The following is a description of a gene set: The gene expression program underlying the specification of human cell types is of fundamental interest. The study authors generated human cell atlases of gene expression and chromatin accessibility in fetal tissues. For gene expression, the study authors applied three-level combinatorial indexing to >110 samples representing 15 organs, ultimately profiling ~4 million single cells. The study authors leveraged the literature and other atlases to identify and annotate hundreds of cell types and subtypes, both within and across tissues. Our analyses focused on organ-specific specializations of broadly distributed cell types (such as blood, endothelial, and epithelial), sites of fetal erythropoiesis (which notably included the adrenal gland), and integration with mouse developmental atlases (such as conserved specification of blood cells). These data represent a rich resource for the exploration of in vivo human gene expression in diverse tissues and cell types. Marker genes curated from the annotated cluster as represented in the Descartes Human Gene Expression During Development database. studied in species Homo sapiens Human Gene Set: DESCARTES_MAIN_FETAL_INHIBITORY_NEURONS from publication Cao J, O'Day DR, Pliner HA, Kingsley PD, Deng M, Daza RM, Zager MA, Aldinger KA, Blecher-Gonen R, Zhang F, Spielmann M, Palis J, Doherty D, Steemers FJ, Glass IA, Trapnell C, Shendure J (PMID 33184181), and this is the list of marker genes: PMCH, DLX6-AS1, DRD3, LHX8, SLAIN1, GRM5P1, PDYN